The following is a description of a gene set: At the center of the mammalian circadian clock is a negative transcription-translation feedback loop (TTFL). In the morning, the BMAL1:CLOCK/NPAS2 heterodimer activates transcription of CRY1, CRY2, PER1, PER2, PER3 and many other circadian-regulated genes. Levels of PER and CRY proteins rise during the day and inhibit their own expression and the expression of other BMAL1:CLOCK/NPAS2-activated genes in the afternoon and evening (inferred from mouse homologs in Cao et al. 2021). During the night, CRY and PER proteins are targeted for degradation by phosphorylation and polyubiquitination, allowing the cycle to commence again in the morning.<br>A secondary loop also exists in the mammalian clock: transcription of the BMAL1, CLOCK, and NPAS2 genes is activated by Retinoid-related orphan receptor-alpha (RORA) and RORC (ROR-gamma) paralogs and repressed by NR1D1 (REV-ERBA), all of which are targets of regulation by BMAL1:CLOCK/NPAS2 and all of which compete for the same ROR regulated elements (RREs, ROREs) in the BMAL1 and CLOCK promoters and in the promoters of many other genes. This mutual control forms a reinforcing loop of the circadian clock.<br>BMAL1 can form heterodimers with either CLOCK or NPAS2, which appear to act redundantly but may show different tissue specificity (inferred from mouse homologs in Landgraf et al. 2016, Reick et al. 2001, Peng et al. 2021). After translation in the cytosol, BMAL1 and CLOCK (and probably NPAS2) are phosphorylated, heterodimerize and enter the nucleus. The phosphorylated BMAL1:CLOCK heterodimers bind E-box elements (consensus CANNTG) in the promoters of target genes (inferred from mouse homologs in Gekakis et al. 1998) and recruit coactivators to enhance transcription of the target genes. Genes activated by BMAL1:CLOCK are expressed diurnally. DBP is among the genes activated by phosphorylated BMAL1:CLOCK/NPAS2 and binds D-box elements in the promoters of many circadian-regulated genes to increase the amplitude of rhythmic expression (inferred from mouse homologs in Yamaguchi et al. 2000).<br>The PER genes (PER1, PER2, PER3) and CRY genes (CRY1, CRY2) are also among those activated by BMAL1:CLOCK and BMAL1:NPAS2. PER gene and CRY gene mRNAs accumulate during the morning and the proteins accumulate during the afternoon. PER and CRY proteins form complexes in the cytosol and these are bound by kinases CSNK1D or CSNK1E, which phosphorylate PER and CRY proteins. Phosphorylation of the PER:CRY:kinase complex is required for its translocation into the nucleus. CDK5 phosphorylates PER2 at serine residue 396 (serine-394 of the mouse orthologue) in a diurnal fashion. This phosphorylation facilitates interaction with CRY1 and nuclear entry of the PER2-CRY1 complex. Within the nucleus the phosphorylated PER:CRY:kinase complexes bind BMAL1:CLOCK heterodimers, inhibiting their transactivation activity and causing dissociation of BMAL1:CLOCK from DNA (inferred from mouse homologs Cao et al. 2021). This reduces transcription of the target genes of BMAL1:CLOCK during the afternoon and evening.<br>During the night PER:CRY complexes are polyubiquitinated and degraded by the 26S proteasome, allowing the cycle to begin again. PER:CRY complexes traffic out of the nucleus into the cytosol due to the nuclear export signal of PER proteins (inferred from mouse homologs in Vielhaber et al. 2001). In the cytosol, phosphorylated PER proteins are bound by Beta-TrCP1, a F-box component of a cytosolic SCF E3 ubiquitin ligase complex that polyubiquitinylates the PER proteins. Also in the cytosol, CRY proteins are bound by FBXL21, another F-box component of a SCF E3 ubiquitin ligase complex that polyubiquitinylates the CRY proteins (inferred from mouse homologs in Hirano et al. 2013, Yoo et al. 2013). In the nucleoplasm, CRY proteins are bound by FBXL3, a F-box component of a SCF E3 ubiquitin ligase complex that polyubiquitinylates CRY proteins (inferred from mouse homologs in Busino et al. 2007). FBXL21 appears to antagonize FBXL3, though the mechanism is not clear.<br>The core circadian clock both regulates metabolism and receives inputs from metabolism. BMAL1:CLOCK,NPAS2 transcriptionally activate thousands of genes, including PPARA, which regulates lipid metabolism (inferred from mouse homologs in Oishi et al. 2005), and NAMPT (inferred from mouse homologs in Nakahata et al. 2009), which is involved in NAD+ metabolism. Retinoid-related orphan receptors (RORs) and NR1D1 also regulate numerous genes, including CPT1A (inferred from mouse homologs in Lau et al. 2004) involved in fatty acid catabolism and SREBF1 (inferred from mouse homologs in Lau et al. 2008) involved in cholesterol biosynthesis. Metabolic inputs include NAD+, which is a substrate in the deacetylation of BMAL1 by SIRT1 (inferred from mouse homologs in Ramsey et al. 2009), and AMP, which regulates the phosphorylation of CRY1 by AMPK, causing enhanced degradation of CRY1 (inferred from mouse homologs in Lamia et al. 2009). Additional metabolic inputs are provided through CLOCK acetylase activity, GSK3beta kinase activity, and casein kinase II (CK2) kinase activity.<br>The circadian clock is cell-autonomous and some, but not all cells of the body exhibit circadian rhythms in metabolism, gene transcription, and cell division. The suprachiasmatic nucleus (SCN) in the hypothalamus is the major clock in the body and receives its major input from light (via retinal neurons) and a minor input from nutrient intake. The SCN and other brain tissues determine waking and feeding cycles and influence the clocks in other tissues by hormone secretion and nervous stimulation. Independently of the SCN, other tissues such as liver receive inputs from signals from the brain and from nutrients.<br>Relationships between the circadian clock and metabolism, disease, and drug efficacy are extensive and are the subject of active investigation.<br>Mice are often used as model organisms for studying the mammalian circadian clock, however some differences exist between mouse clocks and human clocks. For example, peak expression of core circadian genes such as CRY1, CRY2, PER1, PER2, PER3, and NR1D1 occurs about 6 hours earlier in humans than in mice. species: Homo sapiens Reactome Pathway: Circadian clock, and this is the list of marker genes: PSMC1, PSMA6, PSMB6, RPS27A, KMT2A, CPT1A, RXRA, BTRC, CIPC (CLOCK interacting pacemaker), PSMD7, PSMA2, BHLHE41, PER1 (period circadian regulator 1), PPARA, NCOA2, NOCT, SIRT1, NAMPT, PSMD1, BMAL2, RORA, UBA52, MEF2D, TFEB, NR1D1, TBL1X, CUL1, RBX1, UBC, PER3, NRIP1, PSMA1, PSMD2, RORB, TBL1XR1, ADRM1, CARM1, UBE2D1, RORC, SREBF1, PSMA4, PSMD3, CRY1, ATF2, PPARGC1A (PPARG coactivator 1 alpha), PSMB3 (proteasome 20S subunit beta 3), PSMA5, NCOR1, PSMB7, PSMC3, F7 (coagulation factor VII), ELOVL3, RAI1, SMARCD3, CREM, FBXL3, NCOA6, CHD9, PSMA7, BMAL1, FBXW11, NCOA1 (NCBI Gene Id 8648), PSMA3, PPP1CC, CREB1, CRY2, CREBBP, TGS1, SEM1, BHLHE40, PSMC5, PSMC2, SIK1, CRTC3, PSMD12 (NCBI Gene Id 5718), HDAC3, CRTC1, PSMD8, PSMB1, MEF2C, MED1, PSMB5, PSMB4, HELZ2, CSNK2A2, CSNK2A1, CRTC2, PSMD6, SERPINE1, CSNK1E, PER2, DBP, CDK5, KLF15, UBB, CLOCK, CSNK1D, SKP1, FBXL21P, EP300, PPP1CA, CSNK2B (casein kinase 2 beta), NPAS2 (NCBI Gene Id 84195), AVP, PSMD13 (NCBI Gene Id 5719), PSMD14, PSMD11 (NCBI Gene Id 5717), PSMC6, RBM4, PSMB2, PSMC4, PPP1CB